The following is a description of a gene set: studied in species Homo sapiens Generalized muscular hypotonia (abnormally low muscle tone). Human Gene Set: HP_GENERALIZED_HYPOTONIA Generalized hypotonia, and this is the list of marker genes: FLNA, TPM2, WNK1, MANBA, MYPN, TNFRSF11A, KANSL1, ATCAY, MTM1, MPI, SIX3, MYMK, MED13L, DISP1, FDX2, NODAL (NCBI Gene Id 8114), KCNC2, MLYCD, RSPRY1, EZH2, STIL, COA8, EXOSC5, POMT2, ITCH, TBCE, OSTM1, TBC1D24, DYNC1I2, PIGT, SCN1A, TMEM70, CHST3, CPLANE1, CELF2, STT3B, KIF22, ERI1, PNPT1, SCO1, MRPS22, NPC1, MYO18B, PGM3 (NCBI Gene Id 5238), DNA2, MPC1, POMGNT1, SLC45A1, YWHAG, TMEM216, KAT6A, SMN1, EN1, EBP, CHD8, NDUFA11, ATP6V1A, DLD, MYOD1 (NCBI Gene Id 4654), TPI1, TBC1D20, GRIN2D, MCCC2, SERPINH1, EIF2B1, GLDC, MPV17, CHMP1A, TRPS1, SLC25A42, WASHC5, PTCH1, BCS1L, PWRN1, TUBA1A, GALNT2, PLA2G6, ATP1A3, BCKDHA, PPP2R5D, KCNMA1, ELN, TPM3, RNASEH2C, ARL13B, TRIT1, GARS1, OPHN1, EEF1A2, KMT2C, KCNH1, DLL1, CPLX1, ARID2, GPAA1, NAA20, MRPS14, ACTB, GFPT1, GABRA5, FAM149B1, UBE3A, MAG, PUS7, BRAF, ATXN2, B4GALT7, STRADA, NRAS, GRIN2B, AP3D1, BOLA3 (NCBI Gene Id 388962), DHDDS, CYP2R1, PDP1, UBA5, SLC25A20, HACE1, RRM2B, ARHGAP31, TK2, USP7, POC1A, ALG2, WASF1, EED, MYH7 (myosin heavy chain 7), RBM10, CAMK2G, MMADHC, FH, AGK, CACNA2D1 (NCBI Gene Id 781), RETREG1, NARS2, NDUFAF4, ERF, FOXG1, PPP3CA, KCNK9, TMEM67, MSL3 (MSL complex subunit 3), GNB1, HNRNPU, PEX1, PLCH1, TGFB1, PDE6D, GABRB3, TRAK1 (NCBI Gene Id 22906), CYP11B2, POLR2A, CYFIP2, FARSB, NEPRO, GLRX5, GMPPA (GDP-mannose pyrophosphorylase A), CSPP1, ETHE1 (NCBI Gene Id 94930), SCN4A, SDHB, ITPR1, PPP1CB, EBF3, TWNK, SLC1A2, USP18 (ubiquitin specific peptidase 18), AARS1, CLCN7, SLC22A5, ASXL3, OTX2, SLC13A5, SLC46A1 (NCBI Gene Id 113235), KIF7, MYO5A, DNM1L, SZT2, IDH1, PHF6, AMMECR1, SHANK3, PNPLA2, PHF21A, UBE3B, ARX, COQ7, MRPS28, PIK3CA (NCBI Gene Id 5290, phosphatidylinositol-4,5-bisphosphate 3-kinase catalytic subunit alpha), GNAI3, COL6A3, PWAR1, SUZ12, SOX5, MTX2, EP300, ZC4H2, SHH, AP2M1, CNKSR2, PIEZO2, CCDC115, SOX4, AIFM1, TTN, BLTP1, IFT81, LYRM7, AGA (NCBI Gene Id 175), NPAP1, DNAJC12, HCN1 (NCBI Gene Id 609), GRIK2, KIF14, DST, ACADM, KCNC3, ODC1, RNF13, TRMU, ZIC2, GALE, ZBTB18, RORA, MICOS13, PUS3, TBCK, DYRK1A, SLC25A15, DHCR7, CPT1A, PPT1, RLIM, AP3B2, TLK2, NPHP1, HSD17B10, METTL5, KLHL41, PBX1, PLCB4, EMC1, LETM1, FLVCR1, MT-TN, FKTN, LMOD3, TANGO2, CDK8, SYNGAP1, PIGB, NAGA, PIGV, PEX12, YIF1B, NONO, ACAT2, NARS1, GMPPB, MAPRE2, LRPPRC, EXOSC3, PEX3, FZR1, FOXH1, SERAC1, NKX6-2, CLCNKA, FGF12, MKRN3, GABRA2, TRNT1, CHAT, CTBP1, SYNJ1, MAST1, ARL3, PCBD1 (NCBI Gene Id 5092), SETD1A, STT3A, NSDHL, RET, KCNA2, DHX16, RAI1, CHRNE, NEU1 (NCBI Gene Id 4758), CDC42, HEXA, LARGE1, KCNJ10, IQSEC2, COX6A2, SYNE1, KIF1A, ALG12, USP9X, TET3, BMPR1A, IQSEC1, ERCC2, BPTF, AUTS2, RNF113A, KAT6B, SCN3A, TAF1, DDX11, SLC13A3, UGDH, DNM2, PEX14, GCDH, COLQ, ISCA2, PRDM13, DPM2, SNORD116-1, UBR1, EFNB1, STAMBP, NDUFA1, TDP2, ATP6V1B2, HUWE1, CEP104, COL2A1, SLC2A10, MN1, EXTL3, ERCC3, SCN8A, PIGS, ADAM22, DNM1, GALT, CSNK2B, ABCC8, SIX6, TOGARAM1, MED12L, FKRP (NCBI Gene Id 79147), DPM1, EDN1, GABBR2, DCHS1, MAGEL2, SELENON, LRRC32, TSFM, SLC17A5, FMN2 (formin 2), TRIP4, GRID2, CEP290, SUOX, NUP214, LMBRD1, HTRA2, PRF1, ROBO3, CHKB, MAPK1, PAK1, SCN1B, POLG, FLCN, COL6A2, FBXW11, TRAPPC11, COL12A1, HDAC8, TANC2, MSTO1, MAN2B1, SPART, UNC80, KCNT1, FGF8, HADHA, PIGH, GTF2H5, NTRK2, KDM1A, COL1A2, PTEN, TARS1, WWOX, PDHB, HERC2, POU3F3, GM2A, TH, PRKCG (NCBI Gene Id 57013), NUS1, DDX3X, TMEM94, C2CD3, TMEM231, NDUFS3, MCCC1, SSR4, SLC12A2, PTCHD1, MAMLD1, GLB1, SPTBN4, GTF2E2, TIMM50, TMEM237, KCNB1 (NCBI Gene Id 3745), SKI, GFAP, SMS, SNORD115-1, VIPAS39, ACTA1, PTDSS1, GLI2 (NCBI Gene Id 50806), VLDLR, ECHS1, CASR, DAG1, KDM3B, PAX7, COX10, MLXIPL, ALDH5A1, NDUFB8 (NADH:ubiquinone oxidoreductase subunit B8), INPPL1, TMEM63A, GNPTAB, NDUFS2, SLC35C1, ZNF462, BSND, ADSL, SDHD, SLC1A3 (NCBI Gene Id 6507), ACAD9, UBA1, CHD1, HECW2, PUF60, CHST14 (NCBI Gene Id 89881), P4HTM, RMND1, CACNA1A, HLCS, MTMR14, CNTNAP1, STRA6, CRPPA, LONP1, NEB, CDKL5, COL1A1, CUL4B, PEX6, PACS1, KIAA0753, PDHA1, WNK3, TOR1A, SLC18A2, ACTN2, MOGS, SURF1, SLC35A3, GLUL, NSD2, CTU2, BIN1, DDOST, BCL11B, COL6A1, GPX4, NAT8L, NAA10, PRKD1, CARS1, SUPT16H, MYL2, B3GAT3, COL13A1, PUS1 (NCBI Gene Id 80324), KBTBD13, TCTN3, PEX2, LIAS, NEMF, NDUFS7, CRIPTO, GABRG2, SHOC2, SLC38A3, GAN (gigaxonin), PMP22, BMPER, POMT1, SLC35A1, SDHAF1, BUB1B (NCBI Gene Id 701), BCOR, TASP1, LAMA1, PSAP, SGPL1, GAS1, ARFGEF2, AP1S2, SPTAN1, ALG14, VARS1, GCH1, PEX5, GLE1, SPEG, KMT2E, ATXN1, GABRB2, PEX16, NKX2-1, CEP41, NDUFA6, GNPAT, CLCN4, CLCN6, ELP1, APC, FERRY3, RPS23, GNAO1, FARSA, ATXN10, DHFR, MMAA, RPL10, COQ9, COX6B1, COX4I1, NDUFS1, PIGN, OFD1, TSPOAP1, RPGRIP1L, SOX2, PACS2, FASTKD2, LIFR, NDUFA12, SLC25A24, KATNIP, ADARB1, GNE, PNP (purine nucleoside phosphorylase), ACY1, MYH2, OTUD6B, POLR3A, MT-TE, ALG1, PIGG, POGZ, TUBB2A (tubulin beta 2A class IIa), ATP6V0A2, ZEB2, MBOAT7, TOPORS, BMP1, SLC9A7, CACNA1B, MARS2, NRXN1, IFIH1, SETD2, VDR, CANT1, TXN2, FOXP1, FGFRL1, SLC52A2, CD59, DMPK, VPS51, CLTC, NOVA2, SMC1A, SLC9A6 (NCBI Gene Id 53362), PET100, RARS2, MED12, GPHN, CNOT1, COG7, CNOT2, CD96 (NCBI Gene Id 337949), SDHA (NCBI Gene Id 6389), MCOLN1, EXOSC9, ZNHIT3, DALRD3, PLG, CLCNKB, WAC (WW domain containing adaptor with coiled-coil), TBC1D23, CNTNAP2, EIF2S3, POLG2, CDON, SLC25A46, MTOR, CACNA2D2, ATP1A2, GNB2, HADH, STAG2, NANS, MRE11, ARSA (arylsulfatase A), VPS33B, PRNP, LARS1, TBR1, SCN9A, MORC2, SLC25A26, PARS2, CYP27B1, MPLKIP (M-phase specific PLK1 interacting protein), KDM6A, PRDX1, CLP1, COG6, FBXO28 (F-box protein 28), INPP5E, NDUFV2, CDK10, RNU4ATAC, MYF6, TGIF1, ANK3, MKS1, ALG13, AMER1, KIAA0586, PLEKHG2, CPT2, TECPR2, UFM1, ACTL6B, SLC25A10, PRODH, SNRPN, SLC25A4, PMPCA, FLAD1, PIGK, ASCC1, NDUFAF5, KCNN3, NECAP1, MMACHC, COG1, MVK, RYR1, CDK19, DPAGT1, MGAT2